Given this list of marker genes STAB1, SORL1 (NCBI Gene Id 6653), LRP12, OLR1, LRP10 (LDL receptor related protein 10), LRP6, LDLR, LRP2 (NCBI Gene Id 4036), LRP8, LRP1B, CXCL16, LRP1, CD36, STAB2, VLDLR, here is a description of the gene set: species: Homo sapiens Combining with a low-density lipoprotein particle and delivering the low-density lipoprotein particle into the cell via endocytosis. Human Gene Set: GOMF_LOW_DENSITY_LIPOPROTEIN_PARTICLE_RECEPTOR_ACTIVITY